The following is a description of a gene set: studied in species Homo sapiens Neighborhood of DDX5 Neighborhood of DDX5 DEAD (Asp-Glu-Ala-Asp) box polypeptide 5 in the GCM expression compendium Human Gene Set: GCM_DDX5, and this is the list of marker genes: EIF4G2, SET, DDX5, DHX9, ATP5PB, DYRK1A, SPG7, USP14, HNRNPU, SRSF5, COPB1, MSN, PSMD6, TIMM17A (NCBI Gene Id 10440), ESD, ZNHIT3, DNTTIP2, HNRNPL, TCEA1, USP7, NONO, SRP14, PCBP1, EIF4H, ARHGEF7, DDX39B, MAZ, CAPRIN1, KHDRBS1, SUMO2, RABGGTB, DDX18, TCP1, SSR1, RBM3, HNRNPH1, COL16A1, TRA2B (NCBI Gene Id 6434), CBFB, SRSF2, FUS, SRSF4, NAP1L1, BCLAF1, HMGN1, HNRNPD, SMARCC1, PTGES3, HNRNPA1, TAF9, HNRNPM, RB1CC1, YWHAQ (tyrosine 3-monooxygenase/tryptophan 5-monooxygenase activation protein theta), NCL, PNN, AFF1, HNRNPA2B1, RAD21, YWHAZ, NUP153, RAF1, SF1, HTATSF1, MAPRE1, SLC25A3